Given this list of marker genes IBA57, NFU1, FXN, NUBP1, BOLA3, ABCB7, BOLA1, GLRX3, NFS1, NDUFAB1, CIAO1, NUBP2, FDX2, BOLA2B, NDOR1, CIAO3, NUBPL, ISCA2 (iron-sulfur cluster assembly 2), XDH (xanthine dehydrogenase), ISCU, HSPA9, CIAPIN1, HSCB, LYRM4, GLRX5, ISCA1, BOLA2, here is a description of the gene set: studied in species Homo sapiens The incorporation of a metal and exogenous sulfur into a metallo-sulfur cluster. Human Gene Set: GOBP_METALLO_SULFUR_CLUSTER_ASSEMBLY